The following is a description of a gene set: studied in species Homo sapiens Reactome Pathway: Type II Na+/Pi cotransporters The SLC34 family of type II Na+/Pi cotransporters consist of three members; NaPi-IIa (SLC34A1), NaPi-IIb (SLC34A2) and NaPi-IIc (SLC34A3) (Murer H et al, 2004). They are expressed mainly in the kidney and small intestine, located at the apical sites of epithelial cells although other areas of the body express them to a lesser extent. NaPi-IIa and b cotransports divalent Pi (HPO4) with three Na+ ions (electrogenic transport) whereas NaPi-IIc cotransports divalent Pi with two Na+ ions (electroneutral transport). part of: Sodium-coupled phosphate cotransporters, and this is the list of marker genes: SLC34A2, SLC34A3, SLC34A1